The following is a description of a gene set: Gastrulation is the reorganization of the blastula to form the multilayered gastrula. During gastrulation, a portion of cells from the exterior of the epithelial epiblast layer migrate to the interior, where they form mesoderm and endoderm which, together with the outer layer of ectoderm (arising from epiblast cells that have not migrated), comprise the three cell layers that are characteristic of triploblastic metazoans. In the human peri-implantation embryo, epiblast cells ingress through the primitive streak located in the posterior region of the embryonic disc to form the mesoderm and endoderm of the embryo proper. In the mouse, a mammalian model organism, the embryo is cup-shaped instead of being disc-shaped. However, the morphogenetic process of germ layer formation is broadly conserved in both species.<br>The primitive streak forms at the posterior region of the epiblast where there is high signaling activity of NODAL, BMP, FGF and WNT pathways, which drive the allocation of cells to the mesoderm and endoderm lineages. In the primitive streak, the ingressing cells undergo epithelial-to-mesenchymal transition. Cells allocated to the mesoderm acquire a mesenchymal phenotype. Endodermal cells are reputed to revert back to an epithelial architecture through a mesenchymal-to-epithelial transition as they are integrated into the pre-existing layer of hypoblast. A recent study in mouse, however, revealed that ingressing cells that are destined for the endoderm undergo an incomplete or partial-EMT and retain some epithelial features prior to re-acquiring epithelialization.<br>During gastrulation in mice, extraembryonic mesoderm is formed first and is followed by mesoderm that populates the anterior structures, the head, face and heart of the embryo and next the mesoderm to the trunk. Endoderm is also formed in an anterior to posterior sequence, with endoderm emerging early in gastrulation populating the foregut, followed by the mid- and hind-gut. Along the anterior-posterior axis of the primitive streak, endoderm and axial mesoderm emerge from the anterior region, whereas mesoderm emerging from the mid- to posterior regions is allocated in a medial-lateral order to paraxial, intermediate and lateral plate mesoderm. Cells remaining in the overlying epiblast contribute to the ectoderm. Cells of the ectoderm are allocated to the neural ectoderm and to the surface ectoderm and the neural border cells that give rise to the neural crest cells. Patterning of the neuroectoderm is facilitated by the inductive interaction with prechordal plate and the notochord derived from the axial mesoderm.<br>Before ingression, cells of the primitive streak express genes such as TBXT (T, BRACHYURY) and EOMES that are characteristic of nascent mesoderm and endoderm. It is not known if there are common progenitors that give rise to all types of mesodermal derivatives, such as lateral plate mesoderm and paraxial mesoderm. The knowledge to this date indicates that the different types of mesodermal derivatives are allocated in accordance to the timing and locality of emergence from the primitive streak. The existence of bipotential mesendoderm progenitors in the gastrulating embryo is unresolved but unlikely, though a bipotential cell population may be derived from mouse embryonic stem cells in vitro. Reactome Pathway: Gastrulation part of: Developmental Biology studied in species Homo sapiens, and this is the list of marker genes: PAX2, RBPJ, ZIC1, LHX1, SNW1, PSMC4, TCF7L1, EP300, TBXT, FGF8, PSMC1, NOTCH1, PSMB4, SOX2, FOXF1, EOMES, TFAP2C, PSMC6, PSMA2, TBPL2, MAML1, PSMD14, MAML3 (NCBI Gene Id 55534), FGF2, PSMD6, OCLN, MSGN1, HES7, GATA6, SNAI1, PAX6, CDH1, PSMC2, YAP1, KAT2A, FGFR1, NOG, ZIC2, PSMD8, DLL1, MAMLD1, EPHA4, PSMD2, PAX8, GSC-DT, PSMB6 (proteasome 20S subunit beta 6), FOXC1, SHH, GBX2, PSMD12, PSMD11, TFAP2B, ZEB2, FOXA1, GSC, PSMD7, SMAD4, PSMB3, WNT3A (NCBI Gene Id 89780), NOTO, SOX1, LEF1, SMAD2, SMAD3, CLDN7, MYB, KAT2B, SEM1, CREBBP, RIPPLY2, ADRM1, PSMB2, PSMA5, FOXH1, PSMB1, PSMB7, TCF7L2, TRIM33, OTX2, GATA6-AS1, MAML2, FGF4 (fibroblast growth factor 4), TFAP2A, ZNF521, NANOG, OSR1, PAX3, POU5F1, PSMC3, PSMA3, DLL3, FOXC2, POU3F1, PSMA7 (proteasome 20S subunit alpha 7, NCBI Gene Id 5688), FOXA2, DLX5, CTNNB1, TEAD2, SOX17, DEANR1, TCF7, PSMA1, PSMA4, MSX1, PSMD3, TEAD4, MESP2, PSMD13, IHH, TBX6, CXCR4, PSMD1, BMP4, PAX7, MIXL1, PSMB5, PSMA6, PSMC5, LFNG, GATA4